The following is a description of a gene set: Any process that activates or increases the frequency, rate or extent of the process in which the anatomical structures of a neuron projection are generated and organized into branches. species: Homo sapiens Human Gene Set: GOBP_POSITIVE_REGULATION_OF_NEURON_PROJECTION_ARBORIZATION, and this is the list of marker genes: DVL1, GRIP1, DVL2, FZD4, DLG4, DVL3, MAP3K13, WNT5A